Given this list of marker genes Plagl1, Hyls1, Vegfa, Klf3, Gap43, Ldlrad3, Tnip3, Carmil1, Anxa2, Prxl2a, Ost4 (oligosaccharyltransferase complex subunit 4 (non-catalytic)), Myadm, Arid1a, Alyreffm15, Wdtc1, Pcnp, Sv2c, Zbtb45, Ptpn14, Flot2, Synj2bp, Tfcp2l1, Alyreffm17, Alyreffm10, Dgkk, Xkr4, Hook3, Adgrb1, Trim23 (tripartite motif-containing 23), Ckmt2, Ark2c, Tmem141, Atf6b, Dapp1, Thra, Hsh2d, Specc1, Ptbp2, 4921536K21Rik, Zdhhc9, Gsx1, Eif4b, Prickle2, Igf1r, Exd2, Fignl2 (fidgetin-like 2), Pak2, Cnot2, Dpysl5, Klhl29, Rgs7bp, Anks1, Rab5b, B4galt1, Snx27, Ctr9 (NCBI Gene Id 22083), Ppp6r1, Cdc27, Phactr2, Socs3, St6galnac3, Hoxb9, Prkar2b, Tspan18, Nmnat2, Ctbs, Alyreffm11 (Aly/REF export factor family member 11, NCBI Gene Id 100861880), Rnf13, Zfp950, Zmym3, Ralgds (ral guanine nucleotide dissociation stimulator), Tenm2, Bsn, Dcaf8l, Baz2a, Fchsd2, Nid1, Nt5dc3, Gcnt1, Gm15816, Pth, Rgs5, Zfp169, Fam222b, Slc16a14, Itsn1, Alyreffm16, Igf1, Alyreffm13, Rab14, Phlpp2, Tpst2, 0610030E20Rik, Ctnnd1, Ncs1, Cd86, Plxna2, Clvs1, Gstz1, Coro1c, Usp17la, Ifi213, Fbxl17, Zfp385a, Sox6, Luzp1, Prr3, Srcap, Sec14l3, Cd200l1, Alyreffm14, Col11a1, Nr1d1, Tmem79 (NCBI Gene Id 71925), Eif4ebp2, here is a description of the gene set: studied in species Mus musculus Genes predicted to be targets of miRBase v22 microRNA mmu_miR_8113 in miRDB v6.0 with MirTarget v4 prediction scores > 80 (high confidence targets). from publication Chen Y, Wang X (PMID 31504780) Mouse Gene Set: MIR_8113